Given this list of marker genes CHMP6, vif, PDCD6IP, VPS28, CHMP4A, VPS37D, gag-pol, UBC, RPS27A, VTA1, CHMP2B, UBA52, rev, TSG101, CHMP4C, PPIA, gag, NEDD4L, MVB12A, UBAP1, vpr, VPS37C, env, nef, CHMP5, CHMP4B, VPS37B, VPS37A (VPS37A subunit of ESCRT-I), CHMP7, CHMP2A, MVB12B, CHMP3, VPS4A, UBB, VPS4B, vpu, here is a description of the gene set: With the virus components precariously assembled on the inner leaflet of the plasma membrane, the host cell machinery is required for viral budding. The virus takes advantage of the host ESCRT pathway to terminate Gag polymerization and catalyze release. The ESCRT pathway is normally responsible for membrane fission that creates cytoplasm filled vesicular bodies. In this case HIV (and other viruses) take advantage of the ESCRT cellular machinery to facilitate virion budding from the host. Reactome Pathway: Budding and maturation of HIV virion species: Homo sapiens part of: Late Phase of HIV Life Cycle